Given this list of marker genes CDC7, ATRX, AGER, CDT1, CIZ1, E2F7, E2F8, FGFR1, ENDOG, CDK2, SSBP1, DBF4B, WIZ, INO80, DBF4, here is a description of the gene set: Human Gene Set: GOBP_POSITIVE_REGULATION_OF_DNA_TEMPLATED_DNA_REPLICATION Any process that activates or increases the frequency, rate or extent of DNA-templated DNA replication. species: Homo sapiens